Given this list of marker genes TRIM28, SRY, POU6F2, SOX9, KCNQ1, PRKAR1A, PKHD1, SMARCE1, ASXL1, DLK1, EXT2, MEG3, GPC3, FGFR3, BLM, SPRED1, RTL1, H19, GATA4, MAP3K1 (NCBI Gene Id 4214), REST, BUB1B, ARID1B, DICER1, HDAC4, VAMP7, CDKN1C, PTCH1, BMPER, SLC37A4, ARID1A, WT1, PAX6, ZFPM2, PDE11A, C1S, KIT, APC2, CDC73, TRIP13, BUB1, MSH3, GPC4, DPF2, SOX11, BUB3, APC, SKIC3, CEP57, DIS3L2, SMARCC2, ALX4, BCL10, ARID2, TRIM37, DZIP1L, MAD1L1, SMARCA4, SETBP1, PHF21A, SMARCB1, NR0B1, PIK3CA, PALB2, DHX37, TP53, STK11, BRCA2, NSD1, CHEK2 (NCBI Gene Id 11200), NR5A1, MNX1 (motor neuron and pancreas homeobox 1), RB1 (RB transcriptional corepressor 1), FIBP, SKIC2, SOX4, SMARCD1, IGF2, NF1, HRAS, WWOX (NCBI Gene Id 9621), SLC22A18, KCNQ1OT1 (KCNQ1 opposite strand/antisense transcript 1), here is a description of the gene set: Human Gene Set: HP_EMBRYONAL_NEOPLASM Embryonal neoplasm studied in species Homo sapiens